The following is a description of a gene set: The histone H3 lysine 79 methyltransferase DOT1L/KMT4 can promote an oncogenic pattern of gene expression through binding with several MLL fusion partners found in acute leukemia. However, the normal function of DOT1L in mammalian gene regulation is poorly understood. Here we report that DOT1L recruitment is ubiquitously coupled with active transcription in diverse mammalian cell types. DOT1L preferentially occupies the proximal transcribed region of active genes, correlating with enrichment of H3K79 di- and trimethylation. Furthermore, Dot1l mutant fibroblasts lacked H3K79 di- and trimethylation at all sites examined, indicating that DOT1L is the sole enzyme responsible for these marks. Importantly, we identified chromatin immunoprecipitation (ChIP) assay conditions necessary for reliable H3K79 methylation detection. ChIP-chip tiling arrays revealed that levels of all degrees of genic H3K79 methylation correlate with mRNA abundance and dynamically respond to changes in gene activity. Conversion of H3K79 monomethylation into di- and trimethylation correlated with the transition from low- to high-level gene transcription. We also observed enrichment of H3K79 monomethylation at intergenic regions occupied by DNA-binding transcriptional activators. Our findings highlight several similarities between the patterning of H3K4 methylation and that of H3K79 methylation in mammalian chromatin, suggesting a widespread mechanism for parallel or sequential recruitment of DOT1L and MLL to genes in their normal on state. Mouse Gene Set: STEGER_ADIPOGENESIS_DN Genes down-regulated during adipogenesis of 3T3-L1 cells (fibroblast). species: Mus musculus from publication Steger DJ, Lefterova MI, Ying L, Stonestrom AJ, Schupp M, Zhuo D, Vakoc AL, Kim JE, Chen J, Lazar MA, Blobel GA, Vakoc CR (PMID 18285465), and this is the list of marker genes: Maged2, Cmtm3, Rbp1, Timp2, Thbs2, Plat, Capn6, Postn, Mmp2, Pdpn, Fstl1, Cd44, Pdlim2, Osr1, Ogn, Dpt, Dlk1, Timp3, Lox, Pla2g7, Ccn4, Rab3il1, Wnt5a, Rnase4, Olfml3